Given this list of marker genes DIP2A, WDR82, MARK2P19, GLYCTK, RN7SL241P, FGGY-DT, EHBP1L1, LCN8, ENSG00000275358, NKD2, TMEFF2, HMGA2-AS1, LINC01547, here is a description of the gene set: Human Gene Set: ADCYAP1_TARGET_GENES species: Homo sapiens from publication Yevshin I, Sharipov R, Kolmykov S, Kondrakhin Y, Kolpakov F (PMID 30445619) Genes containing one or more binding sites for (ADCYAP1) in their promoter regions (TSS -1000,+100 bp) as identified by GTRD version 20.06 ChIP-seq harmonization.